Given this list of marker genes TSPAN8, CXCL17, IGFBP3, PSCA, SCGB3A1, PIGR, PRSS23, C3, CLU, TSPAN1, CXCL6, TGM2, WFDC2, LCN2, S100P, ELF3, AKR1C1, TMEM45A, AGR2, SAA1, LTF, XBP1, MMP7 (matrix metallopeptidase 7), KRT7, MUC5B, TFF3, CP, BPIFB1, CTSC, RHOV, CYP2F1, ZG16B, SCGB1A1, AQP5, S100A9, GSTA1, MDK, SERPINB3, KRT19, MSMB, CXCL8, KLK11, CEACAM6, SAA2 (NCBI Gene Id 6289), SLPI, MGP, VMO1, CXCL1, RARRES1 (NCBI Gene Id 5918), FAM3D (FAM3 metabolism regulating signaling molecule D), here is a description of the gene set: from publication Gavish A, Tyler M, Greenwald AC, Hoefflin R, Simkin D, Tschernichovsky R, Galili Darnell N, Somech E, Barbolin C, Antman T, Kovarsky D, Barrett T, Gonzalez Castro LN, Halder D, Chanoch-Myers R, Laffy J, Mints M, Wider A, Tal R, Spitzer A, Hara T, Raitses-Gurevich M, Stossel C, Golan T, Tirosh A, Suvà ML, Puram SV, Tirosh I (PMID 37258682) Human Gene Set: GAVISH_3CA_METAPROGRAM_EPITHELIAL_SECRETED species: Homo sapiens In this study, an extensive analysis was conducted to define meta-programs (MPs) capturing intra-tumor heterogeneity across a spectrum of tumor types. The approach utilized non-negative matrix factorization (NMF) to analyze each cell type separately within individual tumor samples. This involved the analysis of malignant cells, macrophages, fibroblasts, endothelial cells, epithelial cells, T-cells, and B-cells. NMF was executed with varying parameter values (K=4, 5, 6, 7, 8, 9), thereby generating 39 programs for each cell type per sample. Each NMF program was summarized by the top genes based on NMF coefficients.\nRobust MPs were then delineated for each cell type using a set of stringent criteria, including recurrence within the same tumor, similarity to programs in other tumors, and non-redundancy within a tumor. Subsequently, these robust NMF programs were clustered (per cell type) based on Jaccard similarity, leading to the identification of MPs associated with each cell type.\nTo enhance the quality of the MPs, a refinement steps were undertaken, involving the removal of MPs suspected of reflecting low-quality data (with an overrepresentation of ribosomal proteins or mitochondrial-encoded genes), single-study inclusion, or similarity to miss-annotated cell types. Genes upregulated in subsets of cells of a given type within various tumors